The following is a description of a gene set: The chemical reactions and pathways resulting in the breakdown of monocarboxylic acids, any organic acid containing one carboxyl (-COOH) group. Mouse Gene Set: GOBP_MONOCARBOXYLIC_ACID_CATABOLIC_PROCESS species: Mus musculus, and this is the list of marker genes: Acad12, Etfa (electron transferring flavoprotein, alpha polypeptide), Cyp4f14, Ehhadh, Acad11, Acot8, Mlycd, Acat1, Cpt2, Acot7, Acox3, Adtrp, Slc16a3, Acaa1a, Echs1, Irs2, Gcdh, Ces1d, Cnr1, Sesn2, Ldhd, Mtln, Acoxl, Cyp4f40, Dbi, Strap, Acox1, Aig1, Pex13, Auh, Abhd1, Cpt1b, Akt1, Lep, Acsl5, Hadh, Phyh, Abcd4, Acsbg2, Cyp26c1, Hadha, Acadm, Ech1, Echdc1, Irs1, Acad10, Ilvbl, Dlat, Akr1d1 (aldo-keto reductase family 1, member D1), Eci1, Agxt2, Abcb11, Twist1, Acadl, Ldhc (lactate dehydrogenase C), Lpin3, Etfbkmt, Hao1, Faah, Decr1, Lpin1, Xylb, Tysnd1, Plin5, Sult2a8, Pex7, Eci3, Crat, Pck2, Crot, Ppard, Lipe, Akr1a1 (aldo-keto reductase family 1, member A1), Slc25a17, Akt2, Slc27a2, Cyp39a1, Nudt19, Obp2a, Acaa2, Etfdh, Echdc2, Fah, Adipoq, Cyp4f15, Sord, Hsd17b10, Cyp2w1, Pex5 (peroxisomal biogenesis factor 5), Slc27a4, Decr2, Lpin2, Hacl1, Cyp4f13, Eci2, Abcd1, Nudt7, Acads (acyl-Coenzyme A dehydrogenase, short chain), Cryl1, Dcxr, Pon3, Mtor, Lonp2, Slc16a1, Hsd17b4, Acox2, Abhd3, Acadvl, Aldh1l2, Abcd3, Cyp4f18, Abhd2, Cyp26b1, Klf9, Ldha, Abcd2, Sp1, Bdh2, Ivd, Agxt, Hoga1, Cpt1a, Acaa1b, Hadhb, Nudt8, Cyp26a1, Pex2, Etfb, Pck1, Scp2, Ces1f, Fabp1, Acacb, Mfsd2a